The following is a description of a gene set: Genes having at least one occurence of the motif TCTGATA in their 3' untranslated region. The motif represents putative target (that is, seed match) of human mature miRNA hsa-miR-361 (v7.1 miRBase). species: Homo sapiens Human Gene Set: TCTGATA_MIR361, and this is the list of marker genes: MED13L, RAD23B (NCBI Gene Id 5887), LGR4, RREB1, DDX3X, ERG, RAC1, ADD3, VEGFA, PRICKLE2, ACTG1, ARMC8, CCDC178 (NCBI Gene Id 374864), CELF6 (CUGBP Elav-like family member 6), SOHLH2, DMRTC2, RAD23A, CLCA3P, MECP2, LINC02873, KPNB1, PATZ1, PEX5, PCDH9, PDE4B, STAU1, RHOA, DIPK2A, MEX3C, MXI1, IL10, CAMK2D, VEZF1, SND1, AFF2, SDK1, MEOX2, STX7, CRY1, YWHAB, LARP4B, RRAGB, DENND1B, ADCY2, MAGI1, RAD21, MYCBP, POLR2M, CTNND2, MTMR4, AP1S3, GOLGA4, BTF3, DPP10, LRP1B, TWIST1, INTS6L, UBE2K, HSP90AA1, UBR5, AEBP2, CPOX, SCAF8, DOCK3, NUP153 (nucleoporin 153), WNT7A, RPA1, ATPAF1, SLC1A3, GPHN, MTRR, DAG1, QKI, FGF7P3, LUC7L3, RANBP17, NHS, ZFPM2, CPSF7, NFAT5, ZNF655, SREK1, ZNF362, SON, CALM3, FGF7P6, USP42, CREBBP, FGF7, CALCRL, SP1, PLP1